The following is a description of a gene set: Genes predicted to be targets of miRBase v22 microRNA hsa-miR-4290 in miRDB v6.0 with MirTarget v4 prediction scores > 80 (high confidence targets). species: Homo sapiens from publication Chen Y, Wang X (PMID 31504780) Human Gene Set: MIR4290, and this is the list of marker genes: SNX8, BDKRB2, CCNT1, CCDC9B, CASP14, TRIB1, FGF9, ELFN2, ENOX2, SEPTIN3, STK32C (serine/threonine kinase 32C), SESN2, STAT3, GID4 (NCBI Gene Id 79018), ADAM11, TMEM192, RPEL1, PPP1R9B, LYNX1, KRT77, SUN1, ZNF276, TIMM23B, MS4A6A, CAMTA1 (NCBI Gene Id 23261), ZFAND6, PRPH2, MYRF, CAPZA1, MAT2A, MAPK1IP1L, ANKRD52, ELMOD2, TMEM265, NUP188, DCTN4, SMG5 (NCBI Gene Id 23381), CXCL12, CLCF1, SORCS2, ZNF185, ERLIN2, MTAP, LINC02881, AWAT1, KDM4A, TSPAN5, ARHGEF2, MAP1B, RGS17, WIPF2, TNKS, HS3ST1, TM2D2, ATP8A2, ARHGEF17, NFASC, PRKDC, MAPK8IP1, PYCR1, RPE, ZNF541, NRBP1, PTPN5, SART3, ERRFI1, AKIRIN2, CTDSP2, CSN1S1